The following is a description of a gene set: Human Gene Set: GOMF_LIGAND_GATED_CALCIUM_CHANNEL_ACTIVITY species: Homo sapiens Enables the transmembrane transfer of a calcium ions by a channel that opens when a specific ligand has been bound by the channel complex or one of its constituent parts., and this is the list of marker genes: GRIK1, MCOLN1, RYR1, TRPV1, P2RX1, ITPR1, GRIN2B, GRIN2A, GRIK3, ITPR3, RYR2, MCOLN2, TRPM2, TRPA1, RYR3, TPCN2, GRIN1, GRIA3, GRIK2, TPCN1, ITPR2, GRIA1, TRPM8, BNIP1, PKD2, P2RX4, MCOLN3, GRIN2D